Given this list of marker genes Stx16, Kmt2d, Gpr132, Eps15, Nme1, Ssbp2, Adnp (NCBI Gene Id 98815), Kat6a, Prkd2, Tab1, Zfat, Ubc, Gtf3c6, Pla2g4a, Tfap4, Rmnd1, Zfp36l1, Armt1, Cltc, here is a description of the gene set: studied in species Mus musculus Mouse Gene Set: ZBTB16_UNIPROT_A3KMN0_UNREVIEWED_TARGET_GENES from publication Yevshin I, Sharipov R, Kolmykov S, Kondrakhin Y, Kolpakov F (PMID 30445619)